Given this list of marker genes Inhba (NCBI Gene Id 16323), Dgkz, Zc3h12d, Rfwd3, Pten, Sde2, Trp53, Fam107a, Ctdspl (NCBI Gene Id 69274), Mir26a-2, E2f7, Rpa2, Cdkn1a, Cdk2ap2, Ezh2, Rps27l, Ptprv, Apc (APC, WNT signaling pathway regulator), Klf4, Dact1, Fbxo7, Ctdsp2, Gpnmb, Fhl1, Dcun1d3, Ccnd1, Wac, Ctdsp1, Men1, Slfn1, Sox2, Mir26a-1, Btn2a2, Mir26b, Bcl2, Trex1, Prkdc, Brd7, Jade1, Cacnb4, Ppp2r3d, Prmt2, Fbxo31, Cdkn2b, Dlg1, Rbl2, Acvr1, Pkd2, Plk3, Susd2, Mettl13 (methyltransferase 13, eEF1A lysine and N-terminal methyltransferase), Gigyf2, Zfp655, Haspin, Myo16, Gpr15lg, Apbb1, Gas1, Tmsb4x, Cdkn2d, Ccl12, Gjc2, Cdc73, Kank2, Rb1, Rbl1, Crlf3, here is a description of the gene set: studied in species Mus musculus Any signaling pathway that decreases or inhibits the activity of a cell cycle cyclin-dependent protein kinase to modulate the switch from G1 phase to S phase of the cell cycle. Mouse Gene Set: GOBP_NEGATIVE_REGULATION_OF_CELL_CYCLE_G1_S_PHASE_TRANSITION